The following is a description of a gene set: Any process that modulates the frequency, rate or extent of store-operated calcium entry. species: Mus musculus Mouse Gene Set: GOBP_REGULATION_OF_STORE_OPERATED_CALCIUM_ENTRY, and this is the list of marker genes: Spg11, Efhb, Casq1 (calsequestrin 1), Stc2, Selenok, Spink1, Homer2, Nfatc3, Tspan18, Saraf, Slc8b1, Cd84, Jph4, Homer1, Trpc4, Gramd2a, Stim1, Homer3